Given this list of marker genes COL9A3, COL9A2, COL9A1, COMP, KIF22, here is a description of the gene set: Fragmented epiphyses Human Gene Set: HP_FRAGMENTED_EPIPHYSES Fragmented appearance of the epiphyses. species: Homo sapiens